The following is a description of a gene set: studied in species Mus musculus Mouse Gene Set: GOBP_BLOOD_VESSEL_ENDOTHELIAL_CELL_PROLIFERATION_INVOLVED_IN_SPROUTING_ANGIOGENESIS The multiplication or reproduction of blood vessel endothelial cells, resulting in the expansion of a cell population contributing to sprouting angiogenesis., and this is the list of marker genes: Thbs1, Epha2, Agtr1b, Nrarp, Pdcd10, Jcad, Agtr1a, Aplnr, Fgfbp1, Sema5a, Gata2, Bmper, Mmrn2, Ngfr, Ppp1r16b, Il12b, Vegfa, Itgb1bp1, Hmox1, Il12a, Apela, Bmp4, Dll4